The following is a description of a gene set: studied in species Homo sapiens Human Gene Set: EVI1_01 Genes having at least one occurrence of the motif WGAYAAGATAAGATAA in the regions spanning 4 kb centered on their transcription starting sites. This matches the EVI1 transcription factor binding site V$EVI1_01 (v7.4 TRANSFAC)., and this is the list of marker genes: ISL1, VAMP3, ASB2, PTCHD4, THBS2, NCBP3, NCAM2, SCUBE3, SPINK4, VCL, SIX1, IKZF2, PTGDR2 (prostaglandin D2 receptor 2), CRAT, GSX1, TOB1